The following is a description of a gene set: Reactome Pathway: Organic anion transport by SLCO transporters studied in species Homo sapiens part of: SLC-mediated transport of organic anions Organic anion transporting polypeptides (OATPs) are membrane transport proteins that mediate the sodium-independent transport of a wide range of amphipathic organic compounds including bile salts, steroid conjugates, thyroid hormones, anionic oligopeptides and numerous drugs (Hagenbuch B and Meier PJ, 2004)., and this is the list of marker genes: SLCO3A1, SLCO4A1, SLCO2B1, AVP, SLCO1C1, SLCO2A1, SLCO1B3, SLCO4C1, SLC16A2, SLCO1B1, SLCO1A2